Given this list of marker genes LCE1E, SPRR2A, LCE3B, KRT79, LIPJ, KRT32, KRT76, EVPL, KRT40, CDSN, LCE2A, KRT3, LCE1C, PCSK6, PKP2 (plakophilin 2), DSC2, LCE2C, DSG3, KRT36, KLK12, SPRR3, CAPNS1, KRT24, SPRR2D, KRT19, LCE4A, DSC3, KRT6B, SPRR2B, KRT35, KRT38, TGM5, LIPN, FLG, KRT78, PRSS8, DSG4, SPRR2G, LCE6A (NCBI Gene Id 448835), KRT5, KRT31, JUP, KRT23, LCE3D (NCBI Gene Id 84648), CAPN1, KAZN, KLK5, KRT71, KRT2, KRT80, CSTA, IVL, PKP3, KRT18 (NCBI Gene Id 3875), TCHH, KRT20, KRT4, KRT9, SPRR2F, DSG1, KRT73, KRT39, LCE3E, KRT33A, LCE1B, ST14, LCE3C, RPTN, KRT33B, PPL, KRT14, LORICRIN, LIPK, KRT27, KLK13, KRT83, FURIN, KRT84, KRT75, KRT8, KRT28, KRT12, SPINK9, LCE2B, PI3, KRT82 (keratin 82), KRT34, DSG2, KRT81, KLK8, SPRR1A, KRT72, LCE5A, LELP1, LCE2D, SPINK5, DSP, KRT6A, PERP, KLK14, KRT26, KRT25, KRT13, KRT37, PKP4, SPINK6, KRT16, CELA2A, TGM1, KRT77, KRT1, LIPM, KRT6C, KRT74, KRT85 (NCBI Gene Id 3891), KRT86, LCE1F, KRT15, LCE1A, KRT7, PKP1, KRT17, CASP14, LCE3A, DSC1, LCE1D, SPRR2E, KRT10, SPRR1B, here is a description of the gene set: species: Homo sapiens Reactome Pathway: Formation of the cornified envelope part of: Keratinization As keratinocytes progress towards the upper epidermis, they undergo a unique process of cell death termed cornification. This involves the crosslinking of keratinocyte proteins such as loricrin and involucrin by transglutaminases and the breakdown of the nucleus and other organelles by intracellular and secreted proteases. This process is strictly regulated by the Ca2+ concentration gradient in the epidermis. Loricrin and involucrin are encoded in ‘Epidermal Differentiation Complex’ linked to a large number of genes encoding nonredundant components of the CE. Keratinocytes produce specialized proteins and lipids which are used to construct the cornified envelope (CE), a heavily crosslinked submembranous layer that confers rigidity to the upper epidermis, allows keratin filaments to attach to any location in the cell membrane and acts as a water-impermeable barrier. The CE has two functional parts: covalently cross-linked proteins (10 nm thick) that comprise the backbone of the envelope and covalently linked lipids (5 nm thick) that coat the exterior. Desmosomal components are crosslinked to the CE to form corneodesmosomes, which bind cornified cells together. Mature terminally differentiated cornified cells consist mostly of keratin filaments covalently attached to the CE embedded in lipid lamellae. The exact composition of the cornified envelope varies between epithelia; the relative amino-acid composition of the proteins used may determine differential mechanical properties.